The following is a description of a gene set: Mouse Gene Set: GOCC_KINETOCHORE_MICROTUBULE studied in species Mus musculus Any of the spindle microtubules that attach to the kinetochores of chromosomes by their plus ends, and maneuver the chromosomes during mitotic or meiotic chromosome segregation., and this is the list of marker genes: Chmp1b, Chmp3, Chmp1a, Chmp5, Rab11a, Chmp1b2, Kif18a, Zw10, Chmp4b, Chmp6, Kntc1, Chmp2b (NCBI Gene Id 68942), Chmp7 (NCBI Gene Id 75967), Cenpe, Bbln, Chmp4c (NCBI Gene Id 74324), Chmp2a